Given this list of marker genes Sec13, Nup43 (NCBI Gene Id 71809), Tpr, Nup50, Nup98, Nup42, Nup160, Seh1l, Ran, Nup85, Ipo8, Aaas, Nup205, Ranbp2, Ndc1, Nup210, Nup37, Nup88, Nup133, Nup58, Nup188, Ago2, Tnrc6a, Pom121, Nup35, Nup62, Nup54, Nup93, Nup107, Nup214, Rae1, Nup153, Nup155, here is a description of the gene set: Mouse Gene Set: REACTOME_TRANSCRIPTIONAL_REGULATION_BY_SMALL_RNAS species: Mus musculus Transcriptional regulation by small RNAs